Given this list of marker genes CD33, CSTA, RAB3A, SCARB1, TMEM14C, HGF, TBC1D14, LILRB5, EEF2K, SOWAHD, ALK, CTNNBIP1, TTC3, KRT73, BAIAP2-DT, KCNJ5-AS1, BNC2 (NCBI Gene Id 54796), TMEM86A, APLP2, KIAA0930, DNAJB13, ASRGL1, PPM1H, PKDREJ, SNHG28, GPC4, SLC4A7, LINC01281, RAB3IL1, RGS18, TNFSF11, AHNAK, ATP6V0D2, RASGRP4, C11orf21, RXRA, MAML3, OPLAH, ADK, ACP3, ATP6AP2, DBH, CD101, LINC02035, CD207, KCNQ1, FRMD4B, CDR2L, DEPDC7, MMP9, IL1A, CARD9, ANKRD18A, NT5DC2, HNMT, ADAM22, CYP1B1-AS1, PRKAG3, ARHGAP20, VSIR, PMFBP1, SLAMF8, PLB1, FCGR2B, CYBB (NCBI Gene Id 1536), PLCB2 (phospholipase C beta 2), LEP, RNASE6, TMC8, MRC2, CCDC170, SNX29, SLC2A9, TBC1D10C, SYK, RFLNB, EPX, ALDH1A1, PALD1, PECAM1, KLF3-AS1, AATK, STK32B, HTR7, STK32C, CTDSPL, C1QA, CLCN5, REPS2, CLEC10A, RNF125, TMEM45B, NRG1, LINC03033, FOLR2 (folate receptor beta), APBA1, TGFBR1, PGLYRP2, FUCA1, LY86, CCR2, DYNC2H1, PRKAR2A, FCGR2A, CAMK1, TOMM7, DPEP3, TMEM170B, SLC48A1 (solute carrier family 48 member 1), BST1, ARHGAP6, HSD11B1, SLC16A6, MATK, PCYOX1, SIGLEC7, APBB1IP, SIGLEC12, TLN2, NOXA1, CCL22, GPAT3, HLF (NCBI Gene Id 3131), DAD1, JAML, FCER2, SORL1, LDLRAD3, GIPC3, PLLP, LIM2 (NCBI Gene Id 3982), LY96, TENM1, RPL4, MPEG1, UCP2, LILRA1, EVI2B, CD300C, MMRN1, FCGR1A, NLRC4, CDHR2, PRXL2B (NCBI Gene Id 127281), COL18A1, S100A8, SPIRE1 (spire type actin nucleation factor 1), GUCY2C, HAL, RORC, PDZD4, TSPAN7, ABHD2, ENSG00000255240, ITFG2-AS1, KRT72, LGR4, TBXAS1, DEPTOR, C16orf74, HSD17B4, SCNN1A, SLC29A3, C12orf57, TRERF1, CPNE9, DEF8, MGST2, COL23A1, AOC1, COLGALT1, STEAP4, IFNGR1, FNDC10, HLA-DMA, GLIPR1, CXCL1, SEMA3A, AMPD2, FN1, TSPAN32, CD93, DSC2, RARRES1, CLMN, SIGLEC9 (NCBI Gene Id 27180), TRPC1, STEAP3, PLXNA1, WNT1, IL18BP, RNASE1, DLG4, CCDC149, CLDN7 (NCBI Gene Id 1366), SHISA8, CNRIP1, SGCD, RTN4R, LTA4H, FABP3, APOE, FOS, RAPH1, DCANP1, SLC27A1, GSTA4, ATP5PB, SDC2, STAC, CHI3L1, CLEC7A, CERK, OXNAD1, TFCP2L1, TENM4, CREB5, PKIB (cAMP-dependent protein kinase inhibitor beta), ABCC5, GRAMD4, KCNJ15, KCNJ5, HSPA7, FGFBP2, LST1, NLRP12, ITGAM, SPAG8, HAMP, P2RY2, VSIG4, NHS, LDHD, EIF4EBP1, VIPR1, PC, TMEM144, CCDC68, TLR6, NRCAM (NCBI Gene Id 4897), LRRC70, VCAN, ASGR1, GATM, HRH2, FADS1, BRI3BP, CMTM4, FAH, ARRB2, IL16, LINC01094, STARD13, SPINT2, HCST, FGD4, EIF3L, KCNC3, RGCC, OLFM1, SEMA6C, TGFBI, PLXDC1, AIF1, LRRC25, BHLHE41, ALDH2 (NCBI Gene Id 217), LINC02908, MARVELD1, LGR6 (leucine rich repeat containing G protein-coupled receptor 6), FAM110C, SIRPD, S100A4, TLR5 (NCBI Gene Id 95519), TXLNB, TPCN1, GFRA2, ESYT1, RPL17, COL19A1, FKBP1A, LAMB3, MIR548AN, PRSS23, SH3BGRL (SH3 domain binding glutamate rich protein like), SIAH3, KRT1, S100A9, AKR7A2, FAM210B, FPR1, SLC16A10, ERBB3, AVPR2, RAB37, PID1, MYCL, TMT1A, SIGLEC15, PTGDR, C19orf84, RASGRF1, CFAP44, PTGS1, NUDT6, CPVL, TSPAN18, UBXN11, CTSA, ADAMTS10, PPT1 (palmitoyl-protein thioesterase 1), MYO7A, PROS1, CD40LG, ARRB1, SH3RF3, LRP1, DPEP2, HLA-DMB, EDNRB, CEACAM19, STXBP1, ARHGDIB, NHSL2, CDHR1, CCN3, DOCK3, INSR, SNX30 (sorting nexin family member 30), KCTD15, CBX7, DNM1, FGF9, PROC, CEBPA, LTBP2, MIR4712, CHST13, STAB1, GASK1B, TMEM71, SLC47A1, CD14, HTRA1, RTL8B, QPCT, TNNI2, NOG, LINC01963, MACROH2A1, SATB2, SERPINE1, TNFRSF10C, ABCC3 (NCBI Gene Id 8714), CACHD1, FES, TSPO, TNFAIP8L2, CELSR1, PADI2, CEACAM3, LINC00304, AP2S1, SLCO2B1 (solute carrier organic anion transporter family member 2B1), SNX18, GGTA1, DTNA, KLHL14, AGAP1, RASGRP2, NRGN, SIRPB2, SMAD6, CPM, PCDH1, GPR82, HTR3A, ADORA3, HOPX, ANOS1, RPGRIP1, EPPK1, ARPIN, SLC17A7, SKAP2, LRP3, PPBP (NCBI Gene Id 90374), WNT10B, CCDC9B, CALM2, CD1C, CCL24, FCGR2C, PCSK6, GLB1L, CR1, WDR17, SELENOP, CYP27A1, CXCL6, THBD, OPRL1, FOXRED2, ITGA11, FAM153A, RBP1, GAS1, TREM2, TOP2B, CATSPER1, FCRL6, CRISPLD2, DTX1 (NCBI Gene Id 1840), DBP, TRIM47, TMEM107, FOLR3, TPBGL, NEXMIF, C10orf55, LRMDA, ATPSCKMT, TNFSF12-TNFSF13, LDLRAP1, GPRC5B, SNCA, FTCDNL1 (NCBI Gene Id 348751), PLBD1, GPRASP2, CD300LF, BLVRB, SIRPG, COTL1 (coactosin like F-actin binding protein 1), SH3RF3-AS1, CENPK, CDA, SLITRK4, SSPN, TMCC2, ANTXRL (ANTXR like), IQCK, SLAMF9, LIME1 (Lck interacting transmembrane adaptor 1), AQP3, MROH6, NFXL1, PRADC1, RASL10A, TIMP2, PRAM1, MINDY1, ADORA2B, EPHB3, TNFRSF8, VENTX, MMP28, VNN1, DSCAML1, VSIG1, CEBPA-DT, PPM1M, CTSF, VAMP8, ICAM4, ZMYND10, PTGFRN, HIP1, LIPA, UNC5B, TRIQK, CHL1, KISS1R, LPL, MRC1, GNB3, GDPD3, FAM13A, ATP2B1, VAT1, CASS4, ACP5, CD36, UACA, PTGDR2, ACOT11, FAT4, GAS7, CYFIP1, PLIN2, DPYD, CLEC4A, TESC, TTLL2, IMPA2, VSIG8, S100A12, PPFIA4, CALU, ZBED3-AS1, SLC40A1, EIF4B, SETD7, GSTM2, APOC1, TRIM2, KANK2, GPR34, PHETA1, RPL10, CD300LB (CD300 molecule like family member b), ZNF185, SPECC1 (sperm antigen with calponin homology and coiled-coil domains 1), MMP7, CD4, NAIP, GNAQ, CSF1R, PFDN5, ARRDC2, TSPAN4, PI16, SPATA6 (NCBI Gene Id 54558), GCOM1, FAM171B, PLAC9, TM6SF1, CRYL1, ESCO2, YPEL3, KLHL41, NFIA, P2RY13, KCNAB2, SLC24A4, RCN3, RPS3A, TDRD6, OTOA, DBNL, ASIC1, ACADVL, CLCN4, ARHGAP18, HAAO, GPX3, SGMS2, ANKRD34A, SLC11A1, ALDH7A1, MLEC, SAMD1, DNAAF11, ALDH3A2, NEFL, RGS12, CD9, FAXDC2, NMUR1, ALOX5, CRIP3, ZNF704, PARM1, PTPRN2-AS1, ST14, GSN, LOXL3, ANGPT1, FCGRT, A2M (NCBI Gene Id 2), SRD5A3, CD209, IL1R1, SLC37A2, NOTCH3, AP1S2, BMF, SH3TC1, SLC46A1, NINJ2, DPCD (NCBI Gene Id 25911), PRSS36, SFRP5, SLC1A5, RGS14, TK2, RASA4, KLHL3, GAPT, PLXDC2, CNN2, RASAL1, TIMP3, LRP5, LINC01547, PAPSS2, C14orf132, GZMA, PNPLA7, DSG2, CAT, MICAL2, RASSF2, ITGB2-AS1, GP1BA, PDGFC, ADI1, STXBP5-AS1, ITGB2, EPS8, NCEH1, MCEMP1, KLF7, CHN2, HHEX, ATP6V0A1, ATP9A, WNT7A, TMEM273, C1orf162, C1QC, PPARG, M1AP, ADAM12, ENSG00000284954, ZFHX3, BMP2 (bone morphogenetic protein 2), DNER, SH3BGRL3, GPNMB, FCRLB, CREBL2, ARHGAP4, SORT1, LILRA2, F13A1, CLEC5A, PLPPR2, PDK4, ST18, FFAR4, ANXA9, LINC00926, FCN1, FXYD7, SLC46A3, KIF5A, SLC47A2, ME1, CTTNBP2, NAT8L, DAB2, MAN2B1, EPHX4, MGAM, SEMA4C, SIGIRR, S1PR1, CPAMD8, NEK6, A2M-AS1, SPARC, DOC2A, SDK2, CYBRD1, CD163L1, VASH1, DSC1, CYP1B1, NLRP1 (NLR family pyrin domain containing 1), MS4A6A, MPZL2, SULT1B1, ARHGEF4, PSTPIP1, SSC4D, SPON1, CXCL5, IQCD, QSOX1, LYZ, ALPK2, RNF130, RAI14, ARAP3, PYGL, SIGLEC10, ERP27, COL6A3, VWF, IER5L (NCBI Gene Id 445576), HEXA-AS1, GAS2L3, LAT2, SUMF1 (NCBI Gene Id 285362), RAB3D, SLC46A2, LINGO3, IGSF22, KLRB1, OXER1, ADAMTS7, CLEC11A, DLEU7, CD52, EPB41L1, NTN4, CRTAP, RPL22, LGALS3, CD27, LINC00622, ZDHHC7, RBL2, ADAM15 (NCBI Gene Id 8751), NHSL1-AS1, ADGRA2, NEFM, TFRC, CACNA2D4, APMAP, DOK2, ASB13, SMIM10L2A, ICAM5, EIF3F, TBC1D30, FCER1A, KCNMB4, PSRC1, TMED10, KLF2, XYLB, OLFM2, ITGB5, DHRS9, CACNA1D, COLEC12, FBP1, NFAM1, here is a description of the gene set: Genes down-regulated in peripheral blood mononuclear cell vaccinated vs unvaccinated in adolescent/young adults (11-22) after exposure to M-M-R II, time point 7Y BACKGROUND: There are insufficient system-wide transcriptomic (or other) data that help explain the observed inter-individual variability in antibody titers after measles vaccination in otherwise healthy individuals. METHODS: We performed a transcriptome(mRNA-Seq)-profiling study after in vitro viral stimulation of PBMCs from 30 measles vaccine recipients, selected from a cohort of 764 schoolchildren, based on the highest and lowest antibody titers. We used regression and network biology modeling to define markers associated with neutralizing antibody response. RESULTS: We identified 39 differentially expressed genes that demonstrate significant differences between the high and low antibody responder groups (p-value <= 0.0002, q-value <= 0.092), including the top gene CD93 (p < 1.0E-13, q < 1.0E-09), encoding a receptor required for antigen-driven B-cell differentiation, maintenance of immunoglobulin production and preservation of plasma cells in the bone marrow. Network biology modeling highlighted plasma cell survival (CD93, IL6, CXCL12), chemokine/cytokine activity and cell-cell communication/adhesion/migration as biological processes associated with the observed differential response in the two responder groups. CONCLUSION: We identified genes and pathways that explain in part, and are associated with, neutralizing antibody titers after measles vaccination. This new knowledge could assist in the identification of biomarkers and predictive signatures of protective immunity that may be useful in the design of new vaccine candidates and in clinical studies. from publication Haralambieva IH, Zimmermann MT, Ovsyannikova IG, Grill DE, Oberg AL, Kennedy RB, Poland GA (PMID 27529750) species: Homo sapiens Human Gene Set: HARALAMBIEVA_PBMC_M_M_R_II_AGE_11_22YO_VACCINATED_VS_UNVACCINATED_7YR_DN